The following is a description of a gene set: Human Gene Set: WP_PSORIASIS_MECHANISMS_AND_THERAPIES studied in species Homo sapiens Psoriasis mechanisms and therapies, and this is the list of marker genes: IL12B, IL17F, CXCL1, IL22, TNF, IL12RB1, IL23R, TYK2, IL23A, CXCL8, HLA-C, IL17A, IL17RC, IL1B, CCL20, CCR6, STAT3, JAK2